Given this list of marker genes Vegfa, Pgf, Vegfb, Vegfd, Flt1, Vegfc, Flt4, here is a description of the gene set: part of: VEGF ligand-receptor interactions studied in species Mus musculus This event has been computationally inferred from an event that has been demonstrated in another species.<p>The inference is based on the homology mapping from PANTHER. Briefly, reactions for which all involved PhysicalEntities (in input, output and catalyst) have a mapped orthologue/paralogue (for complexes at least 75% of components must have a mapping) are inferred to the other species. Reactome Pathway: VEGF binds to VEGFR leading to receptor dimerization electronically inferred by orthology from the curated human pathway